Given this list of marker genes MNT (MAX network transcriptional repressor), NCLN, PIM2, CNOT6, PTK7, RAPGEF2, GTF2H5, GBX2, SH3PXD2B, UBE2G2, IGDCC4, GPC5, EGF, SIX4, SLC5A1, GCC1, RSBN1, SH3BP2, DELE1, TNK2, KLHL29, NDST1, DHCR24 (24-dehydrocholesterol reductase), IL3, AK2 (adenylate kinase 2), SOCS1, SHC2, IRGQ, BAGE2, LSM14A, FOXO3, CCNL2 (NCBI Gene Id 9613), ZSCAN12, TRIM36, ERP29, PLA2G12B, SMAD4, AP5B1, EXD1, FBXW4 (NCBI Gene Id 6468), BICD2, PAPOLG, LRPAP1, WWTR1, ZHX2, KIF3A, SRGAP2B, CDH22, LMAN2L, SPTSSA, FAM107A, PHF21A, SYN1, DVL2, TRIL, TEX261, PDAP1, JADE1, MYRF, ZSCAN22, GPATCH2L (G-patch domain containing 2 like), WASHC4, TMEM208, CDIN1, FERMT2, VTA1, TBC1D2B, MAF1, GPR12, SRGAP2C, FGFRL1, TTL, SPOP, FAM98B, ARF4, PDXK, ATP11C, TMEM126B, EREG, KCTD6, KCND3, DIO3, SLC15A4, ZNF132, RBBP6, ARHGAP36, TMPRSS13, CHMP7, SERTAD4, MPPED1, SLAMF8, NXPH1, LINC02907, PLA2G3, KSR2, AIRE, MTCL2, STT3B, ZMAT2, ATXN7, AP4B1, DOCK11, SRPRA, RANBP10, ARRDC3, GPR171, UBFD1, MSANTD1, THOC2, TLK1, ACTR1A, SLC35B4, OPRM1, SLC51A (NCBI Gene Id 200931), MRTFA, PHTF1, BCR, ERG, CEMIP2, KY, SETD5, here is a description of the gene set: species: Homo sapiens Genes predicted to be targets of miRBase v22 microRNA hsa-miR-4645-5p in miRDB v6.0 with MirTarget v4 prediction scores > 80 (high confidence targets). from publication Chen Y, Wang X (PMID 31504780) Human Gene Set: MIR4645_5P